Given this list of marker genes PPP2R1B, BUB1, NAA50, AXIN2, BUB1B, MEIKIN, BOD1, SGO1, NAA10, CTNNB1, CTCF, PPP2R1A, here is a description of the gene set: Human Gene Set: GOBP_CENTROMERIC_SISTER_CHROMATID_COHESION The cell cycle process in which the sister chromatids of a replicated chromosome are joined along the length of the centromeric region of the chromosome. studied in species Homo sapiens